The following is a description of a gene set: Recurrent meningitis An increased susceptibility to meningitis as manifested by a medical history of recurrent episodes of meningitis. Human Gene Set: HP_RECURRENT_MENINGITIS species: Homo sapiens, and this is the list of marker genes: IL2RG, CFI, WAS, C1QC, MYD88